Given this list of marker genes Mapkap1, Jph2, Rag2, Snx3, Plekha4, Sestd1, Snx14, Pla2g4e, Clvs1, Wdr45b, Tpcn2, Hip1r, Clvs2, Wdr45, Tpcn1, Atp13a2, Washc2, Plek2, Wipi2 (NCBI Gene Id 76581), Wipi1, Commd1, Rs1, Phlda3, Kif16b, Snx5, Plekha5, Sh3pxd2b, Hip1 (huntingtin interacting protein 1), Gbf1, Acap2, here is a description of the gene set: Binding to phosphatidylinositol-3,5-bisphosphate, a derivative of phosphatidylinositol in which the inositol ring is phosphorylated at the 3' and 5' positions. Mouse Gene Set: GOMF_PHOSPHATIDYLINOSITOL_3_5_BISPHOSPHATE_BINDING species: Mus musculus